Given this list of marker genes Fgf2, S100a1, Dll1, Il10, Tjp1, Hmgb1, Pkm, Ghsr, Itga5, Clic3, Tnn, Bmper, Fgf1, Tgm2, Smad1, Shh, Jmjd8, Ghrl, Jak1, Jcad (junctional cadherin 5 associated), Sec1, Hif1a, Pdpk1, Dsg2, Vegfa, Klf4, Fut1, Slc39a12, here is a description of the gene set: Mouse Gene Set: GOBP_POSITIVE_REGULATION_OF_SPROUTING_ANGIOGENESIS Any process that activates or increases the frequency, rate or extent of sprouting angiogenesis. studied in species Mus musculus